Given this list of marker genes ABCB1, SLC30A5, ABCC5, ABCG2, SLC29A4, SLC22A2, SLC17A3, ABCC1 (ATP binding cassette subfamily C member 1 (ABCC1 blood group)), SLC26A6, ABCB6, GJA1, SLC39A9, ABCB5, SLC27A1, ABCC4, XPR1, here is a description of the gene set: studied in species Homo sapiens Human Gene Set: GOMF_EFFLUX_TRANSMEMBRANE_TRANSPORTER_ACTIVITY Enables the transfer of a specific substance or related group of substances from the inside of the cell to the outside of the cell across a membrane.